The following is a description of a gene set: species: Homo sapiens Human Gene Set: REACTOME_PEXOPHAGY Pexophagy, and this is the list of marker genes: EPAS1, UBB, RPS27A, NBR1, UBA52, MAP1LC3B, ATM, UBC, SQSTM1, USP30, PEX5